Given this list of marker genes STRA8, CCNL2, GNPNAT1 (NCBI Gene Id 64841), ATP6V1E2, FAM151B, ADCK5, ZNF281, EPHB2, C3orf38, BCKDHA, TMEM140, XRCC5, TCERG1, NAV2 (NCBI Gene Id 89797), PHKG2, ZMAT1, PLK3, TIAL1 (TIA1 cytotoxic granule associated RNA binding protein like 1), MGAT5, MSMO1, NEU3, RPS9, PTCD1, NUDT19, UPF2 (NCBI Gene Id 26019), IRF4, MED13L, COQ2, CDKAL1, TBCE, HERC1, MAPKBP1, PITX1, TMEM154, NPAS4, TRIM17, ZNF740, FKBP3, NAGA, POLR1A, ASXL2, ARHGAP36, TRPT1, ZRSR2, BAIAP3, HDAC4, TK2, KIAA0040, SLTM, HLA-C, UCP2, DNAJA1, ANKIB1, ERCC4, CYB561D1, RBM33, SPACA1, ALS2, SELENOP, CDA, RSRC2, BLCAP, TOP3B, GSDMD, FKBP8, AIP, ARL13B, AKAP7, PRSS55, SRSF11, NFATC1, KIAA1958, TMEM135, TRMU, CD164, CEP63, TNFRSF9, PARP16, TELO2, AKR1E2, CREB3L2, LONP2, HAUS7, LCLAT1, KLHL35, SMAP2, DPY19L3, ARHGAP45, C18orf54 (chromosome 18 open reading frame 54), LRRC45, RASSF5, PIWIL2, AFG2B (NCBI Gene Id 80051), AHI1, PHF6, TRPM4, EXOSC10, IPCEF1, TEC, TRIM68, ITPKB, CAMSAP1, CANT1, WIPF2, HSBP1L1, TRAF2, F2R, SPART, SPSB3, PIGU, NSMF, KLHL17 (kelch like family member 17), PDK1, AIM2, PLIN2, RIMOC1, CEP95, GPR183, CBX7, TDP2, HTT, NOP14, MARVELD2, CABLES1, RRP1, CBLB, STAU1, CARNS1, CD72, SLC35B3, P2RX4, TUBGCP4, LAG3, PNPLA6, REXO5, PHTF1, MCM3AP, MSI2, CCDC28A, DIS3L, NFAT5, SDAD1, TASP1, CYFIP1, PODXL, CSTF1, PGM2L1, NR2F6, SEC14L1, THNSL2, ICAM1, OTUD6B, AGRN, NEMF, SLC52A3, ALKBH1, APOBEC3B, MAP3K7, TBC1D17, CYP51A1, SMG6, STX5, FSD2, NKX2-3, CXCR6, RMND1, WIPI2, FBXO32, PLCL2, PIK3IP1, TBCCD1, DXO, CLK4, LETM2, ACOT11, SLC35A4, TOR1B, SLC41A1, BRD9, NEB, OTUD4, SUCLG2, SLC35C2 (solute carrier family 35 member C2), CRYBA2, NPEPL1, TRPS1, HSPA4L, IRAK2, CCDC134, HOMER1, MEPCE, CERK, ADAMTS6, SLC26A11, PHKB, DDX60, GRHL1, FGD3, CEP350, CHIC2, here is a description of the gene set: Human Gene Set: GSE20366_EX_VIVO_VS_HOMEOSTATIC_CONVERSION_TREG_UP Regulatory T (Treg) cells that express the FoxP3 transcription factor are essential for lymphoid homeostasis and immune tolerance to self. Other non-immunological functions of Treg cells, such as controlling metabolic function in adipose tissue, are also emerging. Treg cells originate primarily in the thymus, but can also be elicited from conventional T cells by in vivo exposure to low-dose antigen or homeostatic expansion, or by activation in the presence of TGFβ in vitro. Treg cells are characterized by a distinct transcriptional signature controlled in part, but not solely, by FoxP3. For a better perspective on transcriptional control in Treg cells, we compared gene expression profiles of a broad panel of Treg cells from various origins or anatomical locations. Treg cells generated by different means form different sub-phenotypes identifiable by particular combinations of transcripts, none of which fully encompass the entire Treg signature. Molecules involved in Treg effector function, chemokine receptors, and the transcription factors that control them are differentially represented in these subphenotypes. Treg cells from the gut proved dissimilar to cells elicited by exposure to TGFβ, but instead they resembled a CD103+Klrg1+ subphenotype preferentially generated in response to lymphopenia. Genes up-regulated in comparison of TregLP versus Homeo Convert (see Table 1S in the paper for details). studied in species Homo sapiens from publication Feuerer M, Hill JA, Kretschmer K, von Boehmer H, Mathis D, Benoist C (PMID 20231436)